The following is a description of a gene set: studied in species Mus musculus Genes predicted to be targets of miRBase v22 microRNA mmu_miR_8099 in miRDB v6.0 with MirTarget v4 prediction scores > 80 (high confidence targets). Mouse Gene Set: MIR_8099 from publication Chen Y, Wang X (PMID 31504780), and this is the list of marker genes: Erg, Zfp932, Fam107b, Cpne4, Kcnma1, Uck2, Cyp4f15, 4931414P19Rik, Tnrc6a (trinucleotide repeat containing 6a), Vps37c, Pip4k2c, Kcnn3, Reep3, Lrrtm3, Abhd4, Xpo6, Rimbp2, Ddah1, Anapc7, Luc7l3, Usp1, Rab10